The following is a description of a gene set: Human Gene Set: GOBP_RESPONSE_TO_RAPAMYCIN Any process that results in a change in state or activity of a cell or an organism (in terms of movement, secretion, enzyme production, gene expression, etc.) as a result of a rapamycin stimulus. studied in species Homo sapiens, and this is the list of marker genes: HNRNPD, LARP1, AKT1, LIPA, GOLPH3, IFITM5, FOXP3